Given this list of marker genes GLI3, PYCR2, COMP, MFN2 (mitofusin 2), COL6A1, here is a description of the gene set: studied in species Homo sapiens Human Gene Set: HP_INCREASED_LAXITY_OF_ANKLES Increased laxity of ankles